The following is a description of a gene set: Genes down-regulated during differentiation from pre-BI to large pre-BII lymphocyte. from publication Hoffmann R, Seidl T, Neeb M, Rolink A, Melchers F (PMID 11779835) Gene expression profiles of five consecutive stages of mouse B cell development were generated with high-density oligonucleotide arrays from as few as 2 x 10(4) ex vivo isolated and flow-cytometrically purified cells. Between 2.8% and 6.8% of all genes change on differentiation from one cellular stage to the next by at least twofold. The entire pathway involves differential expression of 10.7% of all genes. Previously known expression patterns of genes (like surrogate light chain, RAG-1/2, MHC class II, mel-14 antigen) are confirmed. The gene expression patterns of the proliferating pre-BI and large pre-BII cells on the one hand, and the resting immature and mature B cells on the other hand, are most similar to each other. Small pre-BII cells display a pattern that is transitional between these two groups. Most of the genes expressed in early precursors are involved in general processes, like protein folding or cell cycle regulation, whereas more mature precursors express genes involved in more specific molecular programs (cell surface receptors, secreted factors, and adhesion molecules, among others). Between 19 and genes share a given expression pattern. Combining knowledge about gene function and expression pattern allows identification of novel candidate genes potentially involved in self-maintenance of pre-BI cells, allelic exclusion and pre-B cell receptor signaling in large pre BII cells, cell-cycle arrest of small pre-BII cells, propensity toward apoptosis or anergization in immature B cells, propensity toward cell division and activation in mature B cells, and stage-specific interactions with stromal cells in the bone marrow. studied in species Mus musculus Mouse Gene Set: HOFFMANN_PRE_BI_TO_LARGE_PRE_BII_LYMPHOCYTE_DN, and this is the list of marker genes: Thy1, Zg16, Krt86, Ifit2 (NCBI Gene Id 15958), Ptpn22, St3gal6, Pkib (NCBI Gene Id 19081), Dsg2, Actn1, Tnfaip6, Ada, Chrnb1, Adgrg3, Grb7, Tgtp1, Akr1c13, Ugt1a2, Ltb, Rcn1, Runx2, Ccnd2, Anxa1, Maged2, Frmd6, Emb, Tbxa2r, Thra, Ly6a, Mdn1 (midasin AAA ATPase 1), Ankrd33b, Hspbp1, Entrep3, Hexa (hexosaminidase A), Anxa2, Efnb3, Ppic, Npc1, Klf10, Igll1, Gm14662, Cubn, Gtf2h1, Sema7a, Ahnak, Akr1c6, Mapk8ip3, Ccl5, Fxyd5, Klra3, Socs2, Dntt, Eng, Zyx, Trim21, Gimap4, Siae, Tcn2, Emp1, Itm2c, Sipa1, Hemgn, Stat4, Sqle, Lrfn4, Csf2rb2, Cd9, Mgst2, Dbndd2, Vpreb1a, Wls, Ankrd28, Ctsl, Dab2ip, Elovl6, Ndrg1 (NCBI Gene Id 17990), Gbp7, Bin1, Ssbp4 (NCBI Gene Id 76900), Zpr1, Bcl2